The following is a description of a gene set: Human Gene Set: KYNG_ENVIRONMENTAL_STRESS_RESPONSE_NOT_BY_UV_IN_OLD The accumulation of DNA damage and mutations is considered a major cause of cancer and aging. While it is known that DNA damage can affect changes in gene expression, transcriptional regulation after DNA damage is poorly understood. We characterized the expression of genes in human primary fibroblasts after exposure to three different kinds of cellular stress that introduces DNA damage: 4-nitroquinoline-1-oxide (4NQO), gamma-irradiation, or UV-irradiation. Each type of stress elicited damage specific gene expression changes of up to 10-fold. A total of genes had similar changes in expression of 3-40-fold after all three kinds of stress. We examined transcription in cells from young and old individuals and from patients with Werner syndrome (WS), a segmental progeroid condition with a high incidence of cancer, and found various age-associated transcriptional changes depending upon the type of cellular stress. Compared to young individuals, both WS and old individuals had similarly aberrant transcriptional responses to gamma- and UV-irradiation, suggesting a role for Werner protein in stress-induced gene expression. Our results suggest that aberrant DNA damage-induced gene regulation may contribute to the aging process and the premature aging in WS. Human environmental stress response genes not changed in primary fibroblasts from old donors in response to UV radiation. from publication Kyng KJ, May A, Stevnsner T, Becker KG, Kølvrå S, Bohr VA (PMID 15897889) studied in species Homo sapiens, and this is the list of marker genes: TP53I11, ZNF507, PRSS23, HLA-DQA1, CCNL2, CSDE1, SOX9, GNPNAT1, BNIP3L, FLOT1, AP3B2, GLRX, TAF10, EIF3L, RHOB, HGF, PDE3A, SLC30A5, GALNT2, TAF1C, TPR, CNKSR1, SOX7